Given this list of marker genes Exosc1, Skic8, Patl1, Cnot10, Cnot1, Exosc8, Exosc4, Nt5c3b, Cnot4, Ddx6, Exosc6, Cnot6l, Cnot6 (NCBI Gene Id 216722), Exosc5, Pan2, Eif4a1 (eukaryotic translation initiation factor 4A1), Lsm6, Pabpc1, Edc4, Cnot8, Lsm5, Skic2, Eif4g1, Eif4a2, Parn, Edc3, Dcp1a (decapping mRNA 1A), Lsm4, Cnot3, Lsm3, Lsm2, Hbs1l, Pan3, Skic3, Exosc3, Eif4a3, Exosc7, Eif4e, Exosc9, Cnot7, Cnot9, Dcp1b, Dcp2, Lsm1, Exosc2, Cnot11, Dis3, Paip1, Tnks1bp1, Eif4b, Lsm7, Cnot2, Dcps, here is a description of the gene set: species: Mus musculus Mouse Gene Set: REACTOME_DEADENYLATION_DEPENDENT_MRNA_DECAY Deadenylation-dependent mRNA decay